Given this list of marker genes Tubb4a, Tuba1c, Tubb4b, Ist1, Tuba1b, Tubb2b, Cc2d1b (coiled-coil and C2 domain containing 1B), Tuba3b, Tuba1a, Tubb6 (NCBI Gene Id 67951), Chmp2b, Tubal3, Tuba4a, Tuba8, Chmp2a, here is a description of the gene set: This event has been computationally inferred from an event that has been demonstrated in another species.<p>The inference is based on the homology mapping from PANTHER. Briefly, reactions for which all involved PhysicalEntities (in input, output and catalyst) have a mapped orthologue/paralogue (for complexes at least 75% of components must have a mapping) are inferred to the other species. electronically inferred by orthology from the curated human pathway studied in species Mus musculus Reactome Pathway: Sealing of the nuclear envelope (NE) by ESCRT-III part of: Nuclear Envelope (NE) Reassembly